The following is a description of a gene set: Human Gene Set: HP_CARDIAC_RHABDOMYOMA studied in species Homo sapiens A benign tumor of cardiac striated muscle. Cardiac rhabdomyoma, and this is the list of marker genes: PTCH1, SOX6, IFNG, TSC2, TSC1